The following is a description of a gene set: studied in species Mus musculus Any process that modulates the frequency, rate or extent of a defense response. Mouse Gene Set: GOBP_REGULATION_OF_DEFENSE_RESPONSE, and this is the list of marker genes: Brcc3, Camk2n1, Sec14l1, Ywhae, Dcst1, Wnt5a, Gfer, Fadd, Klri2, Inpp5d, Tlr11, Fpr2, Ptgis, Usp17le, Igtp, Gm12250, Gbp4, Tgfb1, Peli3, Zbp1, Reg3a, Lpcat3, Ido1, Trpv4, Becn1, C1qbp, Dusp10, Pla2g5, Igf1, Il16 (interleukin 16), Tnip1, Ighg1, Raet1d, Kcnn4, Traf6, Cd300a, Il22ra2, Peli1, Il17ra, Csf1r (NCBI Gene Id 12978), Trim30c, Trim45, Sqstm1, Ctss, Mapkbp1, Arf6 (ADP-ribosylation factor 6), Ttll12, Lgals9, Pglyrp2, Ly96, Gramd4, Ifih1, Rnf185, Pbk, Fgr, Emilin1, Extl3, Trim30a, Ednrb, Ube2k, Tlr1, Crk (NCBI Gene Id 12928), Nlrp9c (NCBI Gene Id 330490), Gbp3, Casp1, Serpinb9b, Tspan32, Cxcl1, Ppp6c, Fpr-rs6 (NCBI Gene Id 321020), Cd300lf, Fanca, Spi1, Slamf8, Tac1, Cgas, Serpinb9g, Selenos, Nlrp4c, Mir7578, Dnaja3, Pde2a, Il17rb, Bcl10, Sod1, Il17a, Cebpb, Tlr12, Zc3h12a, Eif2ak2, Proc, Gsdmd, Fancd2, Stat3, Bpifb1, Il18rap, Emilin2 (NCBI Gene Id 246707), Cd44, Daglb, Ythdf3, Pdcd10, Atg5, Smpdl3a, Optn, Adora2b, Irgm2, S100a14, Tarbp2, Cd300e, Psma1, Ptgs2os, Cxcl5 (NCBI Gene Id 29874), Casp3, Pf4 (NCBI Gene Id 56744), Pomc, Usp29, Mdk, Ppt1, Rag1 (recombination activating 1), Sphk1, Ifi207, Lsm14a, Mfhas1, Trim5, Map3k7, Rb1, Gdi1, Polr3g, Ccr2, Il2ra, Ggt1, Sin3a, Usp50, Ppara, Pspc1, Cx3cl1, Pqbp1, Trim31, Casp12, Il6, Ccr1, Elmod2, Dagla, Cd81, Rnf34, Pdpk1, Abhd17a, Macir, Slc15a2, Prkdc, Hspa4, Cebpa, Ifi213, Ndfip1, Cd74, Igf2, Myo1f, Kcnk13, Ankrd17, Ufd1, Acp5, Oas1f, Nr1d2, Nlrx1, Xrcc6, Zcchc3, Lbp, Ier3, Rnf26, C1qtnf12, Cptp, Tlr2, Ccl24, Isl1, Washc4, Zdhhc5, Rhbdd3, Casp4, Phb2, Tnfrsf1b, Trim3, Cd96, Il2, Wfdc1, Gimap5, Hyal2, Ap3b1, Sfpq, Lyn, Esr1, Hspd1, Lrrc19, Nlrp1b, Usp27x, Shank3, Polr3d, Cyp19a1, Tslp (thymic stromal lymphopoietin), Scimp, Ifi208, Nod2 (nucleotide-binding oligomerization domain containing 2), Stat2, Trim65, Dpp4, Aurkb, Clec12a, Irak2, Ephb2, Napepld, Grpr, Ifi209, Plcg2, Il23a, Zdhhc4, Ifi203, Spata2 (NCBI Gene Id 263876), Rab11fip2, Tmsb4x, Rps6ka3, Nlrp3, Ctla2a, Znrf1, Il10ra, Banf1, Znfx1, Serpinb9f, Ulbp1, Il22, Rabgef1 (NCBI Gene Id 56715), Crh, Mmp12, Bcl6b, Adcyap1 (NCBI Gene Id 11516), Klrc1, Lrp8, Shpk, Epg5, Alox15, Htr2a, A2m, Serpinb9e, Hspa8, Akt1, Syk, Rnf31, Tnip2, Mgll, Drosha, Sting1, Cst7, Elp6, Lamp2, Fosl1, Ptgs2, Stap1, Nppa, Mbl2, Nek7, Nploc4, Foxf1, Adipoq, Alpk1, Akna, Fam3a, Rsad2, Ifnlr1, Foxp3 (NCBI Gene Id 20371), Cyld, Nlrp4a, Zdhhc1 (NCBI Gene Id 70796), Znrf4, Fem1a, Clec4n, Chuk, Cd36 (CD36 molecule), Slc15a4, Muc19, Cx3cr1, Npy5r, Tlr7, Evpl, Rab7b, Polr3b, Tkfc, Vsig4, Gper1, Osm, Parp1, Cactin, Tifab, Ahsg, Tlr9, Metrnl, Alox5ap, Oas1a, Nlrp9a, Abhd12, Tlr4, Armh4, Npy, Oasl1, Rnf144a, Ighg2b, Hmgb1, Zmpste24, Ddx39a, Gja1, Mapkapk3, Polr3c, Zdhhc18, Ifi205, Grn, Arg2, Alox5, Ticam2, Tbc1d23, Il33, Xiap, Ptprs, Kars1, Nfkbia, Oas1h, Trem3, Fndc4, Appl2, Eif2ak4, Ppm1b, Ppard, Pik3r6, Gigyf2, Dnase1, Tab1, Trim41, Trim56, Tff2 (NCBI Gene Id 21785), F2rl1, Git1, Slc7a2, Tmem126a, Brcc3dc, Rnf26rt, Il18, Zdhhc12, C3, H2-M3, Pde5a, Mmrn2, Tlr5, Fpr-rs4, Rftn1, Xcl1, Psmb4 (NCBI Gene Id 19172), Ddt, Eif4e2, Il15, Cd160, Mkrn2, Smpdl3b, Lta, Tnfrsf11a, Brd4, Prkca, Ereg, Gps2, Serpinb9h, Tnf, Slamf6, Il10, Cfhr4, Naglu, Ifi214, Mmp8, Tirap, Lrsam1, Atg12, Setd4, Cd86, Ifng, Pum2, Spn, Cd300c, Lrrfip2, Hgf, Ppp1r13l, Oas1c, Pum1, Clcf1, Mul1, Nectin4, Tnfaip8l2, Fcgr2b, Calhm6 (NCBI Gene Id 215900), Sertad3, Card9, Lrfn5, Irf1, Klrc2, Ffar3, Wdfy1, Tnfsf18, Klrb1a, Adora3, Pja2, Riok3, Cd200r2, H2-T23, Otulin, Trim44, Gbp2b, Gpr17, Cck, Cfh, Klri1, Lilra5, Cd14, Nlrc3, Atm, Grb2, Klrb1c, Sema7a, Dhx58, Prkd1, Adamts12, Mcph1, Nfkbiz, Tlr8, Matr3, Dicer1, Klrc3, Ets1, Nr1h2, Il4, Nectin2, Ins1, Usp18, Nr1d1, Serpinb1a, Erbin, Rasgrp4, Med1, Fut7, Adar, Nt5c2, Tlr13, Irak3, Oas1b (2'-5' oligoadenylate synthetase 1B), Lep, Klk5, Zdhhc11, Ltf, Gimap3, Trafd1, Ffar2, Gpsm3, Cckbr, Hcfc2, Casp6, Il1r1, Gata6, Cd24a, Adam8, Hsp90aa1, Clock, Sharpin, Tnfaip3 (NCBI Gene Id 21929), Irf4, Bcr, Pla2g2d, Flot1, Usp38, Sarm1, Irf3, Syt11, Cnr1, Mill1, Mvk, Klre1, Ptpn22, Srebf1, Lgals1, Serpine1, Atat1, Irak1, Pik3r1, Tnip3, Lrrk2, Il27, Lgals2, Ppl, Il17f, Cd200l2, Fcna, Sbno1, Hpx, Tnfsf11, Socs3, Adora1 (NCBI Gene Id 98749), Sh2d1a, Usp15, Cd200r4, Smad3 (SMAD family member 3), Gm15441, Kcnj8, Il13, Ccn3, Cd300ld3, Otop1, Fam76b, Rbm47, Cd200r3, Cav1, Snca, App, Tbk1, Parp9, Nlrp1a, Ifi35, Fpr-rs3, Gkn2, Celf1, Cdh5, Nlrp4e, Lyar, Aim2, Zdhhc3, Havcr2, Ddx3x (NCBI Gene Id 236681), Ythdf2, Pcbp2, Duoxa2, Sucnr1, Ada, Cyba, Nlrp4f, Oas1d, Nlrp12, Zfp36, Cdc37, Ninj1, Rasgrp1, Lats2, Oas1e, Trim12c, Il22b, Inava, Ap1g1, Cma1, Stat5b, Il12b (interleukin 12b), Ttbk1, Oas3, Slc39a8, Apobec3 (NCBI Gene Id 80287), Src, Stat1 (signal transducer and activator of transcription 1), Ctsc, Pim1, Mef2c, Aoah, Xrcc5, Aars2, Treml4, S100a8, Gpr31b, Rtn4, Rbm14, Ogt, Oas1g, Il1rl1, Hspa1b, Dhx33 (DEAH-box helicase 33), Cxcl17, Mapk8, Ivl, Gfi1 (NCBI Gene Id 14581), Tlr6, Lag3, Ripk1, Sirpa, Foxp1, Nop53 (NCBI Gene Id 98700), Socs5, Rnf115, Clec7a, Lrch4, Sfn, D1Pas1, Gprc5b, Tyro3, Ncr3-ps, Akirin2, Rela, Trim21, Cd47, Penk, Trim62, Trim38, Tnfrsf1a, Ubqln1, Cd200, Tax1bp1, Bap1, Ptpn2, Dnase1l3, Stat5a, Gpr108, Arrb2, Nfe2l2, Tap1, Tril, Zdhhc9, Otud4, Ddx60, Vps35, Cpt1a, Casp8, Plscr1 (NCBI Gene Id 54533), Trex1, Trim30d, Trim30b, Lrrc14 (NCBI Gene Id 223664), Lpl, Gpx1, Rora, Clec12b, Dtx3l, Fcnb, Ccl5, Adora2a, Rnf170, Serping1, Duoxa1, Drd2, Cd276, Ncf1, Sirt2, Trim6, Tafa3, Rab34, Ccl1, Susd4, Gbp2, Calhm2, Pmp22, Ticam1, Ecsit (NCBI Gene Id 26940), Ppp2r3c, Scgb1a1, Cd300c2, Setd6, Cep63, Gbp7, Il23r, Hamp, Mettl3, Fgl2, Il21, Sh2d1b2, Nod1, Sh2d1b1, Klrd1, Sbno2, Enpp3, Rnf135, Fxr1, Kat5, Traf3ip1, Lamp1, Map3k8, Elf4, Nfkbil1, Stk39, Serpinb9d, Gbp5, Pparg, Gpatch3, Mapkapk2, Rps19, Bcl6, Myd88, Isg15, Serpinb9, Rnf216, Tspan6, Dhx9, Htra1, Agt, Ffar4, Zc3hav1, Raet1e, Stmp1, Jak2, Clnk, Parp14, Hexim1, Ilrun, Clpb, Fcgr1, Ifna1, Park7, Klrk1, Txk, Traf3ip2, Arg1, Klrb1, Npas2, Fabp4, Hmgb2, Siglece, Nlrc4, Gpx2, Trim32, Nlrp4b, Slc15a3, Fcer1g, Ccdc134, Pik3ap1, Nr1h4 (NCBI Gene Id 20186), Pml, Ifi204, Arnt, Traf3, N4bp1, Nlrc5, Tnfsf4, Ccl3, Lats1, Anxa1, Pdcd4, Mavs, Cd28, Fpr-rs7, Tradd, Ahr, Pten, Ppp2ca (NCBI Gene Id 97777), Arel1 (apoptosis resistant E3 ubiquitin protein ligase 1), Dsg2, Pglyrp1, Tifa, Trem2 (triggering receptor expressed on myeloid cells 2), Ptges, Tnc (tenascin C), Trim15, Ghsr, Clec2d (C-type lectin domain family 2, member d), Ccr5, Creb3, Pvr, Nr1h3, Aoc3, Lyplal1, Ash1l, F12, C2cd4b, Clec4e, Abcc1, Cd274, Nt5e, Ceacam1, Nlrp14, Ifi206 (NCBI Gene Id 240921), Pla2g10, Vav1, Cadm1, Chrna7, Mapk3, Uaca, Nr5a2, Klrb1b, Trim11, Polr3f, Nlrp2, Irf7, Nlrp10, Zp3, Mndal (myeloid nuclear differentiation antigen like), Pgc, Il1b (NCBI Gene Id 16176), Tasl, Gstp1, Tnfaip6, Tyrobp, Mefv, Fcgr3, Gpr4 (G protein-coupled receptor 4), Grp, Appl1, Samhd1, Mir147, Cd200l1, Ikbke, Slc46a2, Nfkb1, Nfe2l1, Ptpn6, C1qtnf3 (NCBI Gene Id 81799), Bst1, Rictor, Rnf125, Nlrp6, Il1rl2, Reg3g, Klrb1f, Apoe, P2rx7, Nlrp5, Nupr1, Phb1, Csnk1a1, Il20rb, Spsb3, Ufl1, Ywhaz (NCBI Gene Id 68643), Ldlr, Crtam, Ripk2, Abr, Pycard, Ccr7, Selenok, Traf3ip3, Cd200r1, Irf2, Irgm1, Gata3, Letmd1, S100a9, Mark4, Fcer1a, Fbxl2, Nono, Ins2, Il22ra1, Cd37, Tomm70a, Unc93b1, Ercc6, Krt1, Dab2ip, Trim25, Nmi, Lacc1, Colec12, Fem1al, Ipo5 (NCBI Gene Id 97586), Lgr4, Acod1, Slc19a1, Ccn4, Ifi203-ps, Unc13b, Ager, Nlrp9b, Pla2g3, Btk, Ghrl, Siglecg, Apoa1 (NCBI Gene Id 11806), Dtx4, Nr1h5, Tlr3, Snx4, Trim12a (tripartite motif-containing 12A), Cd226, Il12a, Smim30, Ptger4 (NCBI Gene Id 19219), Mas1, Cnot7, Pik3cg, Serpinb9c (serine (or cysteine) peptidase inhibitor, clade B, member 9c), Rigi, Prkce, C2cd4a, Ifi211, Ptger3, Klk7, Itch (NCBI Gene Id 77732), Vamp8, Nagk, Ucn, Tap2, Nkg7, Il12rb1, Ifnb1